Given this list of marker genes C6, C5, C7, CLU, C8G, C8B, C8A, C9, here is a description of the gene set: Terminal pathway of complement Human Gene Set: REACTOME_TERMINAL_PATHWAY_OF_COMPLEMENT studied in species Homo sapiens